Given this list of marker genes USP33, SCRN3, ENSG00000291228, UBE2H, HMBOX1, GTF2A1 (general transcription factor IIA subunit 1), RAB14, EIF3J, CTTNBP2NL, CPLANE1, ACTR10, CAB39, NACC1, CSNK1D, FBXO21, NDFIP1, EEA1, HECTD1, BRD7, GPR107, DICER1, CFAP97, GARRE1, STARD7, URI1, PTAR1, GPR153, ZNF302, MED23, MTMR1, GNPAT, VPS13B, IWS1, FOXJ2, UBR5, TTI1, DCTN4, PXYLP1, ZRANB2, ZNF512, RDX, POGK, SLC25A44, CDK2AP1, GOLM2, AGAP4, FNBP4, ZNF133, UPF3A, EIF4ENIF1, VEZT, NAA30, MAEA, ZFAND3, UBP1, SNX5, EDEM3, ANKFY1, AHCYL1, LARS1, EPB41L2, GAPVD1, PRRC2C, ZNF644, ADO, SH3GLB1, PHF10, SOCS4, CAND1, RNASEH1, ANKRD17, HIPK1, DYNC1I2, ZC3H14, TMEM248, MFAP3, OSBPL2, YTHDF1, WDR11, RNF13 (ring finger protein 13), VPS52, OCIAD1, SERBP1, TOB2, ZNF444, SRRM2, UBE2K, KANSL3, MKLN1, ELP1, ASAP2, FBXO45, NCKAP1, TBCK, JKAMP, BPNT2, PRKAB2, CRP, TMEM184C, SLC39A9, YWHAG, SNRNP200, TMED7, KPNA3, SEL1L, RAB10 (RAB10, member RAS oncogene family), TMEM245, RASSF3, HSD17B12, FBXL5, CEP350, USP19, UBA3, ARID4B, CACTIN, NUP133, FAM98A, FAM156A, RAP2A, FOXJ3, RALA, UBA2, AGPAT5, ZNF770, NMD3, SESN3, LUC7L2, ZZZ3, RAB22A, IPO9, ARFGAP1, MON2, TAB2, MFSD8, UBQLN1, FAM219A, CRNKL1, MPC1, YTHDF3, C5orf24, SPTLC1, OSTM1, ZFP14, LRRC8A, DMTF1, KIAA1191, KIDINS220, XPOT, FAM168B (NCBI Gene Id 130074), EVI5, FBXW11, MACF1, UBQLN2, APMAP, GTPBP3, RNF111, PITPNB, SNX12, NEK9, KLF7, ZNF677, TNPO3 (NCBI Gene Id 404679), IPO8, PPM1B, ACAD9, CLCN3, TMEM30A, ERBIN, ZNF507, DCUN1D4, GORASP1, RMDN3, SAP130 (Sin3A associated protein 130), RNF14, SPIRE1, UFSP2, here is a description of the gene set: studied in species Homo sapiens Human Gene Set: GCM_RAB10 Neighborhood of RAB10 Neighborhood of RAB10 RAB10, member RAS oncogene family in the GCM expression compendium